The following is a description of a gene set: studied in species Homo sapiens Any microtubule cytoskeleton organization that is involved in mitosis. Human Gene Set: GOBP_MICROTUBULE_CYTOSKELETON_ORGANIZATION_INVOLVED_IN_MITOSIS, and this is the list of marker genes: ENKD1, NDEL1, NDE1, VCP, PKHD1, HNRNPU, PARP3, PLK2, MAP4, GPSM1, KIF23 (NCBI Gene Id 981), CDCA8, MAPRE1 (microtubule associated protein RP/EB family member 1), GJA1, MAD2L1, SBDS, PTPA, TPX2, SPDL1 (NCBI Gene Id 54908), SMC3, EFHC1, KIF4A, CLASP1, KIF3B, BCCIP, CDK5RAP2, MAP9, TACC1, TACC3, SUN2, ILK, FSD1, MAP10, CKAP5, KAT5, ANKRD53, MYBL2, CEP97, RANGRF, AURKB, FLNA (filamin A), ESPL1, MISP, RACGAP1, LSM14A, WDR62, ZNF207, SMC1A, NDC80, CHMP4B, PAX6, PRC1, TNKS, CLTC, STAG2, PAFAH1B1, SPRY2, RAB11A, RHOA, MZT1, ITGB1, KIF15, CCNB1, UBXN2B, STIL, CHMP2A, NUMA1, CDK1, CHMP4C, STMN1, GPSM2, FGF10, SPRY1, SPAST, BIRC5, CHMP1B, AURKC, EML1, KPNB1, CCSAP, INCENP, CHMP5, PSRC1, NEK2, SASS6, DCTN6, UHRF1, CHMP3, NUSAP1, SETD2, CENPJ, FAM110A, PLK5, SPC25, GOLGA2, WRAP73, CHMP4A, KIF4B, INTS13, PIBF1, PDCD6IP, RCC1, CEP126, GNAI1, CEP192, SPICE1, DYNC1H1, TUBG2, INPPL1, KIFC1, HSPA1B, PCNT, AURKA, KIF11, CHMP7, NUF2, CHMP4BP1, TTK, OFD1, HSPA1A, TBCE, PLK1 (polo like kinase 1), CHMP1A, PKD1, CENPH, FBXW11, TPR, RIPOR2, HTT, CLASP2, CDC20, CHMP6, PRICKLE1, RAE1, AFG2B, ARHGEF10, RAN, DCTN1, ZW10, DRG1, MCPH1, ABRAXAS1, NUP62, CHMP2B, POLDIP2, DCTN2, AAAS, PLK3, ABRAXAS2, DLGAP5 (DLG associated protein 5), KIF2A, STAG1, NUDC, CCDC61, POC1A, VPS4B, MAP1S, SAPCD2, EML3, RMDN1, HDAC3, CENPE, TUBG1, BORA, DYNLT1, CCDC66, CENPA, CHEK2, NEK6, ANKFN1, NSFL1C, TACC2